Given this list of marker genes CHRNA7, LRRC20, OTOR, SLFN12, CBLL1, TRIP10, STAC, SOBP, UNC5B, EPOP, NEK7, SPECC1, MYH14, SPAG6, CXCL2, TAGLN3, ZNF264, LINC00612, CCDC28A, ENPP3, ISLR, HEATR5B, VGLL1, NTRK2, PSMB6, AIPL1 (NCBI Gene Id 23746), INMT, ZNF276, BTK, STX18, IDUA, PROCR, SOX3, MPP2, CLEC10A (NCBI Gene Id 10462), NRIP2, TUFM, RTBDN, MIA, SRCIN1, ITGAE, DENND2B, DSCAM, G6PC3, FANCL, PMP22 (NCBI Gene Id 5376), NUP42, DNAJC17, SLC15A1, SLC4A10, CLMN, CD44, UPK3A, DPEP3, CITED1, NOTCH1, BATF3, SULT1B1, MAPRE3, HAL, CACNA2D3, METRNL, AXL, IFT70B, HCK, RYR3, PLPP3, PTPRJ, LARP7, VPS72, PAX4, MZF1, APOF, CLCA1, CANX, NHSL2, SLC47A1, CUZD1, WRAP73, PDPN, TTC14, NUP54, RBM6, ENDOU, MST1R, TEX13B (NCBI Gene Id 91313), PLCD1, MRPL48, FOXL1, SLC5A2, GP1BB, ZCCHC3, IL1F10, LMNA, BCHE, PLXNC1, TTR, CXXC1, GABRA2, PIGB, UGGT2, MSRA, TCFL5, NAP1L5, PNCK, DGLUCY, MSL3 (NCBI Gene Id 25867), CDHR5, GALR1, PPT1 (NCBI Gene Id 5538), ATP8A2, VPS39, UBAP1, VSX2, ST8SIA4, SLC8A3 (solute carrier family 8 member A3), GALNT11, EEF1A2, RBP7, NDP, SHPRH, DRAP1, GSTK1, TIMP1, RASSF9, TC2N, HYAL3, PLXDC1, HCN1 (hyperpolarization activated cyclic nucleotide gated potassium channel 1), CER1, UBR4, FGA, DES, RAMP1, CD2, TUBA8, BCL7C, RERG, RGR, CHAC1, LOXL2, FGD3, ALPK2, MIXL1, CCNA1, LATS2, PCDH20, SLC25A2, MUC15, ALCAM, CAVIN4, VEGFC, FUT7, PKP1, SHH, CKAP4, MGMT, NXPH1, PTH2R, PPM1D, DCAF4, PECR, RIOK3, KRCC1, TPM2, RBMS2 (RNA binding motif single stranded interacting protein 2), PPP3CC, BMP4 (NCBI Gene Id 652), SMAD1, PROZ, GHRHR, MYH11, GPR50, KCND1, AADAC, MID1, SOX6, ADIPOQ, IGF2BP1, AHCYL2, SNHG11, ZFP57, SEMA4A, GUCY1A1 (guanylate cyclase 1 soluble subunit alpha 1), ACBD3, DTD2, EXOC6, SNX12, CDKN2B, TYR, DNM1, NPFFR2, LIN7B, SDCBP2, TMEM106C, MLH3, HCN2, KCNJ12 (potassium inwardly rectifying channel subfamily J member 12), ALS2, HSPB8, here is a description of the gene set: Human Gene Set: GSE41978_ID2_KO_VS_ID2_KO_AND_BIM_KO_KLRG1_LOW_EFFECTOR_CD8_TCELL_UP species: Homo sapiens Genes up-regulated in KLRG1 low CD8 T effector cells during infection: ID2 knockout versus ID2 and BCL2L11 knockout. from publication Knell J, Best JA, Lind NA, Yang E, D'Cruz LM, Goldrath AW (PMID 23325888) CD8+ T cells play a crucial role in the clearance of intracellular pathogens through the generation of cytotoxic effector cells that eliminate infected cells and long-lived memory cells that provide enhanced protection against reinfection. We have previously shown that the inhibitor of E protein transcription factors, Id2, is necessary for accumulation of effector and memory CD8+ T cells during infection. Here we show that CD8+ T cells lacking Id2 did not generate a robust terminally-differentiated KLRG1hi effector population, but displayed a cell-surface phenotype and cytokine profile consistent with memory precursors, raising the question as to whether loss of Id2 impairs the differentiation and/or survival of effector-memory cells. We found that deletion of Bim rescued Id2-deficient CD8+ cell survival during infection. However, the dramatic reduction in KLRG1hi cells caused by loss of Id2 remained in the absence of Bim, such that Id2/Bim double-deficient cells form an exclusively KLRG1loCD127hi memory precursor population. Thus we describe a role for Id2 in both the survival and differentation of normal CD8+ effector and memory populations.